The following is a description of a gene set: Glucocorticoids play a role in regulation of T lymphocytes homeostasis and development. In particular, glucocorticoid treatment induces massive apoptosis of CD4+CD8+ double positive (DP) thymocytes. This effect is due to many mechanisms, mainly driven by modulation of gene transcription. To find out which genes are modulated, we analyzed DP thymocytes treated for 3 hours with dexamethasone or medium alone, by global gene expression profiling using the Affymetrix technology (MGU74Av2 GeneChip). The data were analyzed with MAS 5.0 imposing a cut off of 1.7 fold in up regulation and 1.35 fold in down regulation. To further filter results we also used the statistical software, SAM (d 0.88 see figure 1s in supplementary data of the above cited manuscript). Results indicate modulation of genes, also confirmed by either RNAse protection assay or Real Time PCR. For data mining we also used Go Miner to explore the Gene Ontology data bank (see tables 1-3 of the above cited manuscript). The overall results demonstrated that dexamethasone caused the down-regulation of genes promoting survival of DP thymocytes (e.g. Notch1, Socs1 and Id3) or the modulation of genes activating cell death through the ceramide pathway (Ugcg, Sgpp1, Degs1 and Gpr65) or through the mithocondrial machinery. Among the latter, there are Bcl-2 family members (Bim, Bfl-1, Bcl-xL and Bcl-xbeta), genes involved in the control of redox status (thioredoxin reductase, TXNIP and idh2) and genes belonging to Tis11 family which are involved in mRNA stability. Our study suggests that dexamethasone treatment of DP thymocytes modulates several genes belonging to apoptosis-related systems that can contribute to their apoptosis. from publication Bianchini R, Nocentini G, Krausz LT, Fettucciari K, Coaccioli S, Ronchetti S, Riccardi C (PMID 16914556) Genes down-regulated in comparison of control thymocytes versus thymocytes treated with dexamethasone. Human Gene Set: GSE5463_CTRL_VS_DEXAMETHASONE_TREATED_THYMOCYTE_DN studied in species Homo sapiens, and this is the list of marker genes: YES1, ATRX, NRGN, DCK, RBM26, GRAMD2B (GRAM domain containing 2B), DEFB4A, STMN3, FMR1 (fragile X messenger ribonucleoprotein 1), SERPINE1, RTRAF, BSCL2, LIN7B, EIF2AK2, MTDH, BLCAP, CRNKL1, ADSL, NXPH1, UBN1, IL12RB2, RAD51AP1, TMEM191C, RSL1D1, UQCRHL, KCTD12, NR3C1, BUB1, CTNNB1, GABPA, SPRR2A, GSR, WDR45B, SMC3, NPC2, DNAJC1, FRMD6, RPS29, G3BP2, DHX40, AXIN2, SATB1, FUT8, HOXB13, HIGD2A, IRGM, CNBP, DNAJC7, HOXD10, NAT1, LRIG1, MKI67, RBBP7, TMOD3, PTPN22, GMNN, DLD, DDX3X, IL7R, HTR4, STMN4, DDOST, PLAUR (plasminogen activator, urokinase receptor), POLA1, COPZ2, GRIK2, POLDIP3, TUB, ERCC4, MAN1A1, CSTF1, CDADC1, USP18, TRAPPC3, PLA2G12A, EIF2S3, RSRP1, ADI1, MTERF2, USP34, NSMCE3, DPEP3, PTRH1, ABCC5, MRPL58, MARCHF7, CCNA1, DCN, ILKAP, TERF1, RPS14, WDFY2, FNTA, CYTIP, CHRNA6, SH3RF1, EMG1, RAP2B, CPQ, LMNB1, IDO1, NMD3, RNF4, CEBPB, RASSF2, RNASEH2A, PRX, PEX19, PRIM2, APLP2, VPS54, BCLAF1, CCR3, CCDC90B, CPA3, TOX4, COPS5, UNC5C, SLC25A36 (NCBI Gene Id 55186), FKBP5, PSMD14, NDRG3, NSA2, LMO4, CD81, HNRNPU, SOX11, SGK1, XRCC6, SLC2A5, UBR7, WDR81, SLC7A11, AKAP12, AVPR2, TNFAIP3, NIPBL, PPIG, DNAJC8, PGRMC1, NFIL3, CA6, PON2, TFPT, ELL2, CDT1, CAPRIN2, H2AC21, NCKAP1L, TRAPPC12, TULP4, DUSP9, RPAP3, ESD, TMED10, ENSA, SPTSSA, CDC26, CCS, GALR1, GADD45A, MYCBP, USP1, BMPR2, VAMP4, CCL21, ADAMDEC1, RFC3, DDIT3, GOLPH3L, MDM1, SNAP91, RC3H2, TAF1C, TIMM17B, SLC7A9, PSMA6, TRIAP1, ACP3, BCL2, EMC2, EDA (NCBI Gene Id 90878), EPCAM, QKI, RBBP9, EPC1, SELENOW, HSP90B1, GLCE, RNF7, CRYGC, POMP, SCN9A, RACK1, CYB5A, TCOF1, MIOS, COL1A1, LSR